The following is a description of a gene set: species: Mus musculus Outer arm structure present on the outer doublet microtubules of ciliary and flagellar axonemes. Outer dynein arms contain 2-3 heavy chains, two or more intermediate chains and a cluster of 4-8 light chains. Inner and outer dynein arms have different functions in the generation of microtubule-based motility. Mouse Gene Set: GOCC_OUTER_DYNEIN_ARM, and this is the list of marker genes: Dnah17, Dnah9, Odad1, Dnal1, Dnai1 (dynein axonemal intermediate chain 1), Cfap70, Dync1i2, Ccdc103, Dnah5, Dnah8, Dnai2, Nme8